Given this list of marker genes LTBR, IL18R1, LY6E, FGB, HLA-F, PAX5, CD72, KLRC1, CD22, FLT3, KLRK1, CCR5, FGA, CR2, MGST3, GNLY (NCBI Gene Id 7843), IFI44, TNFSF10, HLA-DRA, OASL, TFF1, EDN1, RUNX3, HLA-DOA, CXCL6, LILRB3, GBP1, CR1, INSIG1, GRN, IL1A, MST1R (NCBI Gene Id 5755), CREG1, CD6, BTG1, MIA, SERPINF1, BCL2, EMP1, PTGER4, DPP4 (NCBI Gene Id 1803), CNR2, GATA3, IFI27, CHRM3, PSPHP1 (phosphoserine phosphatase pseudogene 1, NCBI Gene Id 8781), NAMPT, VTN (vitronectin), CD14, C1S, CCR1, UBE2C, DAB2, CXCL12, GCG, ADRA2A, FASLG, IL3, IRF7, IL2RG, XCL1, BPI, SKAP1, ITK, FGF6, NCF4, CD247, EVI2A, CAMP, PDGFB (platelet derived growth factor subunit B), CEBPE, HLA-C, OSMR, CDK5R1, AGRP, CXCL10, FYB1, IL1RAP, TFF3, PSMB9, IFITM1, FCGR3A, GZMA, VIPR1, NR4A2, LRP1, CD4, S100B, PPBP, CEBPB, HBEGF, GPX3, PDGFRA, EGR4, AIRE, CFHR1, IL15, CCN1, C8B, MYC, SLAMF1 (NCBI Gene Id 6504), PF4, BCL6, CCL17, NFKBIA, LILRB4, MS4A1, CCL7, SPOCK1, HFE, FAS, TNFSF12, HLA-DRB5, CD5L, IFITM3, STAT1, DNAJC3, HLA-A, CFH, IL24, LILRB5, GPR65, PGLYRP1, SELL, CCR9, CD53, ZEB1, DEFA4, IL7R, ETS1, FCGR2A, C8A, SFN, MX1, CD8A, CD79B, LGALS3BP, C4BPB (NCBI Gene Id 725), IGF1, CD81, CYBB, CCL11, ARHGDIB, C8G, IFNGR1, AREG, F2, PTN, CXCL5, CD86, CD3G, CSRP2, DEFB1, ORM1, AIM2, P4HA2 (NCBI Gene Id 8974), CAPG, HTN3, CD83, ERG, OPRK1, LILRA3, CLEC2B, C6, HLA-G, CXCL1, BST2, SH2D1A, PRF1, CSF1, CTSG, CCL21, F8, GRAP2 (NCBI Gene Id 9402), CD40, CTSS, FCER1G, PDCD1, C5AR1, IL4R (NCBI Gene Id 3566), CCL4, CD27, IL6R, CD69, LILRA2, BATF, EGF, REG1B, CCL18, CCL3, CXCL8, FCN2, CD19, C1R (complement C1r), CFI, C4B, SFTPD, TNFSF14, IL11, CFB, IGSF6, C5, EPS8, IL1R1, CSF3, GBP2, CX3CR1, HP, LAMP3, IL17A, CD59, LTB, FYN, IGF2, IFITM2, PDGFA, MS4A2, CLU, PYY, CCL23, SAA1, CCL1, LILRB2, CX3CL1, TGFB3, KIR2DL4, CD55, ADORA2A, CEACAM1, CD24, LST1, ZFP36L2, S1PR2, CCL20, ITGB2, RAG1, LY6H, LIF, IL6ST, EREG, IL16, CCL2, KLRC2, F3, CD79A, CLC, C9, TGFBI (NCBI Gene Id 982), OSM, GPR183, CSF3R, LILRA1, CXCL13, NCF1C, VIP, C1QA, C7, CCL8, ISG15, CD1B, IL2RB, C3AR1, SELP, SERPING1, STAT3, FCGRT, CD3D, IGLL1, MX2, C2, TNFRSF13B, IFIT1, AZGP1, CD8B, NCF2, IL18, FGR, CD101, CCL13, IL15RA, TLR2, TACSTD2, SEMA3C, CST7, FCGR3B, ENTPD1, ADRA1D, TNFSF11, CFP, OAS1, NAB2, CXCL2, TYROBP, UMOD, AFP, MGST2, STAT5A, CXCR4, TIMP1, PTMS, CD2, PRKD1, KLRA1P, FGG, CXCL9, C3, CD48, CIITA, CRIP1, PRG2, GEM, NPY1R, LSP1, HLA-DMB, IL27RA, IL9, FCN1, CXCR2, LTF, LBP, CXCL11, MAD1L1, FGF7, LILRB1, KIR3DL1, CHIT1, IFNGR2, BCAT1, ENPEP, ALCAM, CCR2 (NCBI Gene Id 90262), MDK, CCL14, LCP2, MTHFR, APOE, DEFA5, FGF9, CCL19, SH2B2, ADA, KCNN4, MXD1, EMP2, LAT, IL1B, IRF8, CSF2RB (NCBI Gene Id 3564), KLF6, BST1, B2M, CD5 (CD5 molecule), PTAFR, EDNRA, TLR1, CD1C, GAS6, GALR3, AKR1C3, GBX2, DEFB4A, ST6GAL1, FCER1A, ERBB2, HLA-B, IL6, LY86, MPO, CRLF1, C4BPA (complement component 4 binding protein alpha), IRF1, FN1, THPO, RNASE6, TIRAP, ISG20, NPY, SEMA4D, NRP1, AQP9, CCL15, CD300C, UBD, TGFA, EMP3, PSTPIP1, TPSAB1, EDA, CXCL14, IFIT5, LTA, CTSC, MNDA, ORM2, here is a description of the gene set: Genes in the cancer module 46. Human Gene Set: MODULE_46 studied in species Homo sapiens